Given this list of marker genes KCNQ4, SPTAN1 (spectrin alpha, non-erythrocytic 1), ESPN, TMC2, RIPOR2, ACTB, CHRNA10, OTOG, EPB41L1, KCNN2, SLC26A5, MPP1, MYO15A, EPS8L2, SPTBN1, PLS1, ACTG1, CHRNA9, RDX, EPS8, KCNMB1, TRIOBP, TWF1, MYO7A, WHRN, MYH9, CIB2, CLIC5, LHFPL5, USH1C, TWF2, EPB41L3 (NCBI Gene Id 8730), PCDH15, GRXCR2, GRXCR1, ESPNL, USH1G, MSN, TMC1, MYO3B, ATP2B2, GSN, EZR, TMIE, MYO3A, MYO1C, FSCN2, CASK, OTOGL, CDH23, KCNMA1, PJVK, XIRP2, STRC, TPRN, here is a description of the gene set: Human Gene Set: REACTOME_SENSORY_PROCESSING_OF_SOUND_BY_OUTER_HAIR_CELLS_OF_THE_COCHLEA species: Homo sapiens Sensory processing of sound by outer hair cells of the cochlea